Given this list of marker genes ABCB10, SLC25A37 (NCBI Gene Id 55881), LDB1, SLC6A9, PRMT1, KLF4, here is a description of the gene set: Any process that activates or increases the frequency, rate or extent of the chemical reactions and pathways resulting in the formation of hemoglobin, an oxygen carrying, conjugated protein containing four heme groups and globin. Human Gene Set: GOBP_POSITIVE_REGULATION_OF_HEMOGLOBIN_BIOSYNTHETIC_PROCESS species: Homo sapiens